The following is a description of a gene set: species: Homo sapiens Human Gene Set: MIR4747_5P from publication Chen Y, Wang X (PMID 31504780) Genes predicted to be targets of miRBase v22 microRNA hsa-miR-4747-5p in miRDB v6.0 with MirTarget v4 prediction scores > 80 (high confidence targets)., and this is the list of marker genes: SLC9A5, KCNN3, ANKRD52, GAB2 (NCBI Gene Id 9846), SRPK1, AGO1, AHCYL2, TNKS1BP1, CCDC97, SRSF10, AMMECR1, LCE2A, ZER1, SHROOM4, RAD1, VCL, HOXD11, CFL1, IKZF3, SHANK1, CDC42, GLG1, IFI44L, SMARCC2, CSTB, NTRK2, STAG1, KCNG3, SORT1, P3R3URF-PIK3R3 (P3R3URF-PIK3R3 readthrough), CHRNB4, ZFP3, PLSCR3, CPSF7, CACNA1E, ELFN2, BEND3, PRKD3, GNAO1, ZFYVE26, MOSMO, RAP1A, ATP1B2, TPM4, SDK1, RUFY2, SLC25A22, APBA1, KPNA6, SCRN1, SPHKAP, MECP2, SAMD4B, CREB3L1, ADRA1A, PHF21A, CBX7, ZNF444, FBXO42, GPER1, TNPO2, NAV2 (NCBI Gene Id 89797), RPRD1B (NCBI Gene Id 58537), C11orf68, C2orf49, WDTC1, DRD4, OTOF, TRDMT1, STIM1, IRF2, JPH4, PDPR, EPHA5, GAPDHS, SLC3A2 (solute carrier family 3 member 2), CSNK1G1, TAF4, CD1C, CFAP70, FAM20B, VPS37C, BAZ2A (bromodomain adjacent to zinc finger domain 2A), ATG13, NKX3-1, KMT5B, MICAL2, CLMN, HOXC13, ITGA11, LINGO1, AAMP, HEYL, UCP2, UBTF, FBXO41, TEAD1 (TEA domain transcription factor 1), PATL1, FGF12, TNF, DNAAF11, GTPBP3, ZNF319, TRIM27, PYM1, PACS1, FBXW11, PXYLP1, NRF1, SRRD, TFPI, YWHAE, LSM5, ADRB3, TAL1, XKR4, PAXX, OTP, MPZL2, ATP2A1, SPRY4, DUSP10, THAP11, HIP1, SON, CCDC157, CTDSP2, HDDC3, SMURF1, GSG1L, LUZP1, CFAP61, MTCL2, PLIN4, RIMS4, FBXL20, RB1CC1, WDR82, HCLS1, KREMEN1, PRKAG1, RD3, KCNB1, PRDM1, DKK3, FOSL2, CELSR2, MYO1D (myosin ID), TIAM1, PHKA1, GLYR1, NCSTN, ST3GAL2, TNFSF8, CSTF2T, EPHB2, PAAF1, ADCY1 (adenylate cyclase 1), GRIN2D, KDM7A, PHF24 (NCBI Gene Id 23349), RNF122, MYO9A, TMEM178B (transmembrane protein 178B), SLC19A2, POGZ, ILRUN, KLK5 (kallikrein related peptidase 5), SGPL1 (sphingosine-1-phosphate lyase 1), GLT6D1, ATP2B4, DLK1, ZNF385A, SHISA6, MBOAT2, SLC17A7, KAT7, FMOD, GJB1, AFAP1, RELL2, SIX1, UBR2, KCNG4, PIK3R3, SLC8A1, MBNL3, CRY2, CDK4, MBD6 (methyl-CpG binding domain protein 6), WNT9B, ROCK2, SMARCC1, VPS53, LASP1 (NCBI Gene Id 3927), ATP8A2, ZIC1, NKD1, PIANP, LAMC1, ODF1, TRAM2, STEAP4, TM9SF1, TMEM253, TNFAIP8L2, DHX58, ZNRF1, SPATA31D4, HIPK1, ZMYND11, PGAP4, MTHFSD, NFIA, HSPA12A, RAB3C (RAB3C, member RAS oncogene family), CEACAM1, MSC, FKBP5, NIPAL4, ANKRD45, DOK3, INSYN2B, PSME3, ELF2, AP2M1, ATXN7L3, ARID4A, TAOK3, ZDHHC5, PLEKHS1, SLC7A8, BCL9, ESRRG, CORO2B, HTR1B, PEAK1, CASQ1, TBC1D13, DGKK, CD22, RBM22, CAPZA1, UBAP1, KRTAP4-8, DISC1, SRF, LZTS1, XYLT1, MYADM, MTF1, SZRD1, RXRB, LY6G6C, FBXO11, AAK1, POU2AF1, IQSEC3, SLC37A2, HDAC1, PHF1, SCAMP5, MMP15, ZBTB20, SLC6A11 (solute carrier family 6 member 11), MEF2D, SMAP2, FAM3C, NDUFA10, CCNT1, SPTB, HLA-E, ANKRD44, PARP14, NDE1, GDA, PURG, SUSD6